Given this list of marker genes Mmp3, Kras, Egfr, Sos1, Grb2, Hbegf, Hras, here is a description of the gene set: Mouse Gene Set: REACTOME_EGFR_TRANSACTIVATION_BY_GASTRIN EGFR Transactivation by Gastrin species: Mus musculus